The following is a description of a gene set: studied in species Mus musculus Mouse Gene Set: GOMF_CILIARY_NEUROTROPHIC_FACTOR_RECEPTOR_BINDING Binding to a ciliary neurotrophic factor receptor., and this is the list of marker genes: Osmr, Ctf2, Clcf1, Cntf, Crlf1, Lifr, Il6st